Given this list of marker genes Gm24717, Gli1, Mir26a-2, Tmem198b (transmembrane protein 198b), Gm25764, Gm18755, Cyp27b1, Or6c66b, Ndufa4l2, Gm35405, Gm31793, 1700025K04Rik, Gm15900, 9030616G12Rik, Rpsa-ps2, Pmel, Rdh19, Coq10a, Pym1, Rdh1 (retinol dehydrogenase 1 (all trans)), Pa2g4 (NCBI Gene Id 18813), Zc3h10, Mir6915, Mir6917, Rdh5, Cs, Or6c212, Esyt1, Gm23182, Or9k2, Smarcc2, Lrig3, Gm23996, Mir546, Rdh7, Or9k7, Dgka, Gm5181, Gm9176, Gm23664, Cnpy2, Or6c217, Or6c6b, Lrp1, Mip, Slc16a7, Vmn2r85, Or9r7, Or6c221-ps1, Gm6283, Dnajc14, Gm23241, Or6c202, Gm6333, Or6c200-ps1, Ftl1-ps2, Vmn2r87, Or6ac1-ps1, Mars1, Rdh9, Gm23819, Or9k2b, Or6c208, Gm4178, Pan2, Stat6, Rps26, Or6c215, Gdf11 (NCBI Gene Id 14561), Zbtb39, Gm30539, Slc39a5, Pip4k2c, Arhgap9, Or6c69, Cd63, Gm6336, Or6c218-ps1, Or6c35, Mir378d, Gm47949, Olfr778-ps1, Gm4556, Or10p21, Or6c2b, Gm4189, Gm9182 (predicted gene 9182), Or6c5, Gpr182, Mettl1, Rnf41, Or6c207, Apon, Neurod4, Rdh18-ps, Nemp1, Gm10310, Or6c214, Or6c5b, Tespa1, Or6c76, Or6c70, Eef1akmt3, Rab5b, Gm26876, Prim1, Inhbe, Gm16217, Agap2, Naca, Or6c1, Tac2, Myl6, Slc26a10, Or6c201, Nab2, Or10p22, Gm26347, Sarnp, Or6c68, Stac3, Spryd4, Or6c6, Suox, Dctn2, Vmn2r84, Or6c6c, Ptges3, Or10p1, Ctdsp2, Marchf9, Gm9111, Or10u3, Cdk4, Nxph4, Or6c205, Gm36719, Gm25494, B4galnt1, Timeless, Avil (NCBI Gene Id 11567), Or6c63-ps1, 4930484H19Rik, Ddit3, Or6c1b, Nabp2, Or6c33 (NCBI Gene Id 258670), Shmt2, Or6c211, Or6c204, Or6c219, Os9, Bloc1s1, Tmt1b, Or10u4, Gm40797, Atp23 (ATP23 metallopeptidase and ATP synthase assembly factor homolog), Gm47438, Or6c206, Or6c75, Or6c2, Or6ab1-ps1, Mir6916, Gm20492, R3hdm2, Mir8105, Or6c3, Gm9102, Gm10120, Or6c74, Mir6914, Snord59a, Gm9560, Or6c69c, Apof, Or9r3, Or6c8, Or6c203, Dtx3, Mbd6, Ormdl2, Or6c216, Gm16230, Stat2 (NCBI Gene Id 80602), Mir677, Mmp19, Rpl41, Tsfm, Myl6b, Arhgef25, Rdh16, Or6c5c, Rbms2, Itga7, Or6c7, Inhbc, Tspan31, Or6c76b, Cdk2, Kif5a, Gm24179, Or6c88, Baz2a, Or6c38, Gls2, Gm4510, Or6c65, Or6c210, Il23a, Or6c213, Or6c209, Sdr9c7, Gm23793, Hsd17b6, A730063M14Rik, Or6c3b, Vmn2r86, Erbb3, Atp5f1b, Or6c8b, Ikzf4, 1700021G15Rik, Rdh16f2, Ankrd52, Or6c69b, Ctdsp2-ps, Or6c66, Or6o1-ps1, Myo1a, Or10i1-ps1, here is a description of the gene set: Mouse Gene Set: chr10D3 studied in species Mus musculus